The following is a description of a gene set: Human Gene Set: HP_NON_MOTOR_SEIZURE A seizure with clinical manifestation but without motor signs (other than possible behavior arrest) as its initial clinical manifestation. The electrographic onset may be generalized, focal, or unknown. species: Homo sapiens Non-motor seizure, and this is the list of marker genes: CASR, DHFR, ATP1A2, ALMS1, NSD1, SRPX2, AFG2A, SCN9A, RAI1, GABRA1, ARX, FAR1, KIF4A, AP2M1, ADGRG1, CEP85L (centrosomal protein 85 like), TUBB3, HNRNPU, YWHAG, CACNA1H, CILK1, CRELD1, SLC6A1 (NCBI Gene Id 6529), DNM1, PIGM, PIGA, MICAL1, PNKP, DEPDC5, GABRA3, NEUROD2, MAPK10, GNAI1, SLC25A22, PUM1, WWOX (NCBI Gene Id 9621), KCNB1, DHDDS, SON, NHLRC1 (NHL repeat containing E3 ubiquitin protein ligase 1), PLCB1, CLCN2, RFX7, ATAD3A, CAPRIN1, OTUD7A, ALDH7A1, PPP3CA, HNRNPK, SLC35A3, SCN1A, SMO, GNAO1, GABRD, KCNQ3, TREX1, EEF1A2, AFF3, TUBA1A, CIC, LAMA2, CSTB, GRIN1, CUX2, BCKDK, PHGDH, NPRL3, PDE2A, PIGP, LGI1, SCN2A, GLUD1, UBE3A, NFKB2, PCDH19, SATB1, SCN1B, KCNA1, MAST3, DPM3, ZBTB18, ZEB2, DPM1, FRRS1L, EIF4A2, NADK2, ASAH1, ADPRS, TRMT10A, GRM7, CACNA2D1, FBXO28, EPM2A, GABRG2, TRIM8, ADNP, ECM1, ADGRV1, MTHFS, WDR26, PAFAH1B1, PIGT, SETD1B, RNU4ATAC, CNTN2 (contactin 2), PI4KA, PRMT7, ALDH4A1, EZH2, CACNA1A, JRK, CNTNAP2, NEDD4L, WAC, SMPD1, SLC12A5, TRPM3, MECP2, CAMK2A, SMARCA2, PPP2CA, GLUL, HCN1, PGAP2, PACS1, CACNB4, PGAP1, GPAA1 (NCBI Gene Id 8733), KCNQ2, NTRK2, SYNGAP1, CASK, MTHFR, KCNMA1, SZT2, GDI1, COL3A1, MYT1L (NCBI Gene Id 4662), PAK3, PRRT2, SLC38A3, CLCN4, NUS1, KCNH5, GPT2, GOSR2, GATAD2B, RELN, AFG2B, SLC32A1, STX1B, KCNC2, FGF13, NEXMIF, SIK1, NUBPL, CLPB, ALDH5A1, SCN8A, EHMT1, CHD2 (NCBI Gene Id 283680), AHDC1, GAL, SPTAN1, DOCK7, APC2, GNB1, KCNT2, NBEA, GJA5, CDK13, KCNT1, FZR1, DMXL2, HNRNPC, EFHC1, DYRK1A, PTEN, GLI3, TUBB2B, NGLY1, ZFX, GJA8, CDKL5, PIGQ, GABRB3, PLPBP, ATP1A3 (NCBI Gene Id 95633), ATP6V0C, NPRL2, SATB2, TBC1D24, SLC2A1, KPTN, MEGF8, RORB, GRIN2A